Given this list of marker genes Gusb, Spn, Lgals3, Clec4b1, Smim29, Adcy7, Higd2a, Anp32a, Cd300lg, Zfp710, Fbrsl1, Fosb, Akap13, Ctss, Celf2, Nr4a1, Ramp1, Ccnd1, Plbd1, 9930111J21Rik2, Atp5f1c, Hexa, Hexb, Pdlim2, Myl12b, Rp9, Polr2e, Emb, Nsa2, Slc2a3, B4galt6, Exosc5, Irag2, Cd33, Eif4a2, Ptpro, Ighm, Bin1, Ccl9, Lpin1, Sec14l1, Myo1f, Fbxl20, Bnip3l, Pink1, Trf, Ptp4a2, Sulf2, Pak1, Fau, Gpsm3, Prcp, Ndufc2, Tm6sf1, Gpr34, Laptm5, Stx16, Eif3e, Smim14, Nav1, Stk17b, Fam111a, Dpy19l1, Ccpg1 (NCBI Gene Id 72278), Prr5l, Itm2b, Fam117b, Mef2c, Snx21, Sec11c, Crybg3, Foxp1, Zfp36l2 (zinc finger protein 36, C3H type-like 2), Eef2, BC028528, Otulinl, Arrb1, Dapp1, Niban1, Lyz2, Il16, Ifngr1, Evi2a, Aph1c, Selenop, Npc2, Pstpip1, Top2b, Ptprc, Ubac2, Cyfip2, Rnd3, Nsmaf, Btg2, Pld4, Tnfaip8l2, Cyp27a1, Il6ra (interleukin 6 receptor, alpha), H2-DMb1, Khk, Cd81, Txnip, Tyrobp, Slc48a1, Plxdc1, Mapk14, Akr7a5, Tbc1d9, Utrn, Eif3f, Ckb, Gpi1, Fam107b, Csf1r, Lmo1, Mink1 (misshapen-like kinase 1 (zebrafish)), Aif1, Slc35c2, Sla, Iqgap2, Pnpla7, Scarb2, Abhd17a, Idh2, Rbfa, Klhl24, Il17ra, Lmo4, Tifa, Arsb, Pdcd4, Rnase6, Anxa1, Hes6, Cd200r1, Cd37, Lyst, Klf2, Arhgap25 (NCBI Gene Id 232201), Fxyd5, Xpr1, H2-Oa, Ctdsp2, Sh3bgrl3, Tle5, Dctpp1, Hpgd, Cox7a2l, Zbtb20, Atraid, Atp5mc2, Arhgdib, Grn, Creg1, Parp1, Mxd4, Acaa2, Tent5a, Abca9, Mapk3, Arl5c, Cd7, Gsn, Alox5ap, Arhgef6, Nfatc2, Ptp4a3, Stk38, Tut4, Cx3cr1, Psap, Epb41l2, Wdfy2, Sox4 (NCBI Gene Id 20677), Cybb, Pid1, Septin9, Rack1, Igsf6, Il6st, Dna2, Lamtor4 (NCBI Gene Id 66096), Ndufa6, Prkacb, Fes, Tmcc1, Cbl, Egr1, Susd3, Ogt (O-linked N-acetylglucosamine (GlcNAc) transferase (UDP-N-acetylglucosamine:polypeptide-N-acetylglucosaminyl transferase)), Arhgap9, Arl4c, Plekhm3, Rgs2, Ppp3ca, Septin6, Cuta, Tmem59, Trappc5, Rhob, Rnf130, Arhgap17, H2az2, Add3, Atp5if1, Tmem50a, Smim5, Dhrs7, Gpx4, Tnrc6b, Cerk, Fos, Arhgap15, Rgs18, Skint3, Ypel3, Tep1 (NCBI Gene Id 546226), Tbl1xr1, Adipor1, Dusp1, Mbnl1, Kmt2c, Cd180, Septin3, Ncf2, Retreg1, Ctsh, Tsc22d3, Slc46a3, Bri3, Camk1d, Smpdl3a, Pals2, St8sia6, Rgs10, Kctd12, Cd300c2, Sgpp1, Taok3, Sptssa, Oxct1, Ccl6 (NCBI Gene Id 20305), Shtn1, Deptor, Man2b1, Gtf2a2 (general transcription factor II A, 2), Erp29, Ubl3, Trps1, Tkt (transketolase), Klf4, Pabpc1, Mgat1, Tsc22d4, Calhm2, Macf1, Ccr2, Neat1, Limd2, Adgre1, Lbh, Ptpn18, Gdi2, Gltp, Pold4, Dipk1a, Ier2, Atp6ap1, Tpd52 (NCBI Gene Id 99538), Ucp2, Ssh2, Dock2, Marchf1, Dapk1, Ttc7, Degs1, Arl11, Slc15a4, Arhgap45, Cox4i1, Lipa, Slc43a2, Rnf166, Zfp36, Eif4b, Bcl11a, Ttc3, Zeb2, Ppfia4, Pgls (NCBI Gene Id 66171), Selenoh, Sirpa, Plxnd1, Git2 (NCBI Gene Id 80654), Cir1, Gm2a, Serinc3, Cdkn1b, H2-DMa, Bmyc, Cat, Irf2bp2, Plekhg3, Hps3, Gpx1, Tnfaip8, Nfam1, Dnajb14, Mcemp1, Fuca1, Marveld1, Flt3, Slc66a2, Lpar6, Itgb7, Map4k2, here is a description of the gene set: species: Mus musculus from publication Cui A, Huang T, Li S, Ma A, Pérez JL, Sander C, Keskin DB, Wu CJ, Fraenkel E, Hacohen N (PMID 38057668) Cytokines mediate cell-cell communication in the immune system and represent important therapeutic targets. A myriad of studies have highlighted their central role in immune function, yet we lack a global view of the cellular responses of each immune cell type to each cytokine. To address this gap, the authors created the Immune Dictionary, a compendium of single-cell transcriptomic profiles of more than 17 immune cell types in response to each of 86 cytokines (>1,400 cytokine-cell type combinations) in mouse lymph nodes in vivo. A cytokine-centric view of the dictionary revealed that most cytokines induce highly cell-type-specific responses. For example, the inflammatory cytokine interleukin-1β induces distinct gene programmes in almost every cell type. A cell-type-centric view of the dictionary identified more than 66 cytokine-driven cellular polarization states across immune cell types, including previously uncharacterized states such as an interleukin-18-induced polyfunctional natural killer cell state. Genes negatively differentially expressed in cell type: cDC2 (conventional dendritic cell type 2) upon treatment with cytokine: IL-36α in mouse lymph nodes in vivo. Mouse Gene Set: CUI_CDC2_IL36A_RESPONSE_DN